Given this list of marker genes CIC, ACAP2, UBE2S, PBX3, AGRN, CCNB1, PLEC, LARP1 (La ribonucleoprotein 1, translational regulator), TPX2, LTBP1, CLEC3B, MYO1D, SREBF1, FCHO1, MME, TNXA, PPL, NT5E, CDC42EP4, MOXD1, TMEM158, ZFP36, PKIG, IRS1, DNM1, ADCY9, CDC25B, ZFP36L2, MGRN1, MAF, TNC, here is a description of the gene set: Genes up-regulated in hypertrophic scar fibroblasts in response to IL6. from publication Dasu MR, Hawkins HK, Barrow RE, Xue H, Herndon DN (PMID 15095275) Human Gene Set: DASU_IL6_SIGNALING_SCAR_UP The structural rearrangement of collagen fibres in hypertrophic scar causes abnormal contracture, low tensile strength, and raised scars, which cause functional impairment and disfigurement. It is hypothesized that changes in the genes of cytokines, extracellular matrix proteins, and proteins regulating programmed cell death are related to hypertrophic scar formation. To test this hypothesis, fibroblasts were cultured from hypertrophic scars and their response to interleukin-6 (IL-6) stimulation was studied by defining their gene expression profiles. Affymetrix gene chip analysis was used to identify up- or down-regulation in the genes present in the affymetrix array. RT-PCR and ELISA assays were used to validate microarray expression profiles further. Comparison of gene profiles showed an increase of genes in hypertrophic scar fibroblasts compared with normal skin fibroblasts, while the expression of genes decreased. Thirty-three genes were affected by IL-6 treatment in the hypertrophic scar fibroblasts, while genes were affected in normal skin fibroblasts. Messenger RNA to beta-actin ratios for matrix metalloproteinase-1 (MMP-1) and MMP-3 were increased with IL-6 in normal skin fibroblasts from 2.43 +/- 0.06 to 5.50 +/- 0.45 and from 0.75 +/- 0.09 to 1.98 +/- 0.01, respectively. No change in these matrix metalloproteinases could be shown with IL-6 stimulation in hypertrophic scar fibroblasts. Secreted protein levels of pro-MMP-1 and MMP-3 were elevated in the supernatants from normal skin fibroblasts from 2.00 +/- 0.09 and 1.72 +/- 0.10 ng/ml to 4.60 +/- 0.12 and 3.41 +/- 0.20 ng/ml, respectively, after treatment with IL-6 (p < 0.05). No changes were observed in hypertrophic scar fibroblasts treated with IL-6. Values are means +/- SEM. The absence of any up-regulation of MMP-1 and MMP-3 in hypertrophic scar fibroblasts, in response to IL-6, suggests that suppression of matrix metalloproteinases may play a role in the excessive accumulation of collagen formed in hypertrophic scars. While the pathogenesis of abnormal hypertrophic scars remains poorly understood, the use of gene expression arrays may prove helpful in identifying the mechanisms responsible for this type of abnormal scar formation and in formulating an effective therapeutic protocol. studied in species Homo sapiens